Given this list of marker genes Gcm1, Ypel1 (yippee like 1), Ehd4 (EH-domain containing 4), Peak1, Cd46, Zfp946, Samd4, Snta1, Col24a1, Maea, Tmem144, Tmem167, Sub1, Samd5, Aplf, Dmd, Smad3, Tm4sf1, Atp6v1c1, Mfsd13a, Tmem145, Dio2, Atmin, Pcdhb11, Srsf6, Btbd3, Tradd, Naa50, Sptlc3, Chd3, Src, Dusp26, Fbln5, Plxna4, Fcho1, Fat3, Sgsm1, Gsk3b, Hoxa4 (homeobox A4), Pde10a, Adgrg2, Hk2 (hexokinase 2), Capn11, Pbx1, Grik2, Nrgn, Ep300, Rexo5, Macrod2, Dclk1, Daam1, Ctsc, Mgme1, Mbnl1, Greb1l, Hamp2, Phyh, Rapgef6, Tbx20, Ahsa2, Pnn, Cpne8, Rbfox1, Txnrd2, Enkur, Zfp820, Tmem178, Rb1cc1 (RB1-inducible coiled-coil 1), Serpina1a, Tob2, Plekha8, Fam43a, Ciao1, Tbx3, Scn1a, Ark2c, Klhdc10, Bad, Lonrf3, Mtmr3, Eif5b, Sohlh1, Ubn2, Jag1, Srrm2, Pxylp1 (2-phosphoxylose phosphatase 1), Sec16a, Gtpbp8, Bmp3, Basp1, Nrxn3, Sh3d19, Serpina3n, Gabrb2, Aak1, Esyt1, Atp8b2, Zfand3, Rif1, Ldb3, BC024139, Nod2, C8a, Slc25a53, Mfhas1, Ppp1r3e, Shb, Mansc1, Srp72, Crppa, Celsr2, Hand2, Ap1g1, Clip4, Rnf222, Emx2, M1ap, Or51e1, Arhgap35, Ephb2, Elavl4, Abcb8, Dync2h1, Fbxl14, Cmpk2, Mef2d (NCBI Gene Id 99483), Smg7, Ctnnal1, Aanat, Purb, Lrig1, Acss3, Sema3d, Ccdc62, Dync1li1, Treml2, Nox4, Clrn3, Rictor, Ss18l1, Ggt5, Sh3bgrl2, Tbl1xr1, Urb1, here is a description of the gene set: Mouse Gene Set: MIR_6961_3P Genes predicted to be targets of miRBase v22 microRNA mmu_miR_6961_3p in miRDB v6.0 with MirTarget v4 prediction scores > 80 (high confidence targets). from publication Chen Y, Wang X (PMID 31504780) species: Mus musculus